The following is a description of a gene set: Melanoma Human Gene Set: WP_MELANOMA species: Homo sapiens, and this is the list of marker genes: MAPK1, MAP2K2, CALML3, POLK, E2F2, PREX2, PAK1, PIK3R2 (NCBI Gene Id 5296), MITF, SHC2, TP53, BAK1, RAC1, KIT, RAF1 (Raf-1 proto-oncogene, serine/threonine kinase), CDK6, MAPK3, CDKN2A, CDH1, GADD45B, GRB2, PIK3CD, DDB2, PIK3R3, GADD45A, CCND1, VCL, ARAF, STK19, PTEN, E2F1, LAMTOR3 (late endosomal/lysosomal adaptor, MAPK and MTOR activator 3), CALM2, CALML6 (calmodulin like 6), CALM1, GRM3, E2F3, AKT1, RB1, CALML5, NF1, AKT2, PIK3CA, KRAS, MDM2 (NCBI Gene Id 84825), PIK3R1, CALML4, BAX, BRAF, MAP2K1, CALM3, CDK4, ERBB4, SOS2, HRAS, ELK1, CDKN1A, NRAS, PIK3CB, KDR, ETS1, BAD, FOS, GRIN2A, CREB1, AKT3, GADD45G, SOS1